Given this list of marker genes SLC35C1, SLC35D2, SLC35B4, SLC35B3, SLC35A3, SLC35A1, SLC35D1, SLC35A2, SLC35B2, here is a description of the gene set: species: Homo sapiens part of: Transport of vitamins, nucleosides, and related molecules Reactome Pathway: Transport of nucleotide sugars Nucleotide sugars are used as sugar donors by glycosyltransferases to create the sugar chains for glycoconjugates such as glycoproteins, polysaccharides and glycolipids. Glycosyltransferases reside mainly in the lumen of the Golgi apparatus and endoplasmic reticulum (ER) whereas nucleotide sugars are synthesized in the cytosol. The human solute carrier family SLC35 encode nucleotide sugar transporters (NSTs) which can mediate the antiport of nucleotide sugars in exchange for the corresponding nucleoside monophosphates (eg. UMP for UDP-sugars). Owing to their function, NSTs are primarily located on Golgi and ER membranes (He L et al, 2009; Handford M et al, 2006; Ishida N and Kawakita M, 2004).